The following is a description of a gene set: A single cancer cell contains large numbers of genetic alterations that in combination create the malignant phenotype. However, whether amplified and mutated genes form functional and physical interaction networks that could explain the selection for cells with combined alterations is unknown. To investigate this issue, we characterized copy number alterations in 191 breast tumors using dense single nucleotide polymorphism arrays and identified genes with copy number gain organized into 30 amplicons. Amplicons were distributed unequally throughout the genome. Each amplicon had distinct enrichment pattern in pathways, networks, and molecular functions, but genes within individual amplicons did not form coherent functional units. Genes in amplicons included all major tumorigenic pathways and were highly enriched in breast cancer-causative genes. In contrast, genes with somatic mutations in breast cancer were distributed randomly over the genome, did not represent a functionally cohesive gene set, and were relatively less enriched in breast cancer marker genes. Mutated and gained genes did not show statistically significant overlap but were highly synergistic in populating key tumorigenic pathways including transforming growth factor beta, WNT, fibroblast growth factor, and PIP3 signaling. In general, mutated genes were more frequently upstream of gained genes in transcription regulation signaling than vice versa, suggesting that mutated genes are mainly regulators, whereas gained genes are mostly regulated. ESR1 was the major transcription factor regulating amplified but not mutated genes. Our results support the hypothesis that multiple genetic events, including copy number gains and somatic mutations, are necessary for establishing the malignant cell phenotype. Genes within amplicon 20p13 identified in a copy number alterations study of 191 breast tumor samples. from publication Nikolsky Y, Sviridov E, Yao J, Dosymbekov D, Ustyansky V, Kaznacheev V, Dezso Z, Mulvey L, Macconaill LE, Winckler W, Serebryiskaya T, Nikolskaya T, Polyak K (PMID 19010930) Human Gene Set: NIKOLSKY_BREAST_CANCER_20P13_AMPLICON species: Homo sapiens, and this is the list of marker genes: GFRA4, SPEF1, CENPB, ADAM33, ADISSP, SIGLEC1, HSPA12B, ATRN